The following is a description of a gene set: studied in species Mus musculus A cation channel that opens in response to binding by extracellular glutmate, but only if glycine or D-serine is also bound and the membrane is depolarized. Voltage gating is indirect, due to ejection of bound magnesium from the pore at permissive voltages. Mouse Gene Set: GOMF_NMDA_GLUTAMATE_RECEPTOR_ACTIVITY, and this is the list of marker genes: Grin2a, Grin2b, Grin3a, Grin3b, Grin1, Grin2d, Grin2c